The following is a description of a gene set: The process in which an antigenically naive T cell acquires the specialized features of an effector, regulatory, or memory T cell as part of an immune response. Effector T cells include cells which provide T cell help or exhibit cytotoxicity towards other cells. Mouse Gene Set: GOBP_T_CELL_DIFFERENTIATION_INVOLVED_IN_IMMUNE_RESPONSE species: Mus musculus, and this is the list of marker genes: Il27, Clec4e, Socs5, Rorc (RAR-related orphan receptor gamma), Mir873a, Smad7, Il4, Tmem98, Myb, Mir326, Malt1, Ccl20, Nfkbiz, Rara, Cracr2a, Spn, Pck1, Entpd7, Brd2, Ptger4, Rora, Mtor, Stat4, Shb, Tbx21 (T-box 21), Irf4, Nfkbid, Hmgb1, Mir301, Zbtb7b, Prkcz, Tnfsf18, Zc3h12a, Ccr6, Il6, Il6ra, Pf4, Il4ra, Batf, Tbk1, Ep300, Lef1, Men1, Relb, Atp7a, Eomes, Il18, Ccr7, Clec4d, Il18r1, Rc3h2, Stat3, Loxl3, Il12b, Slamf6, Zfp35, Il23a, Bcl6, Pik3r1, Fgl2, Ripk2, Gadd45g, Ifng, Itgb6, Kmt2a, Gpr183, Otud5 (OTU domain containing 5), Tsc1, Il21, Foxp1, Ccl19, Ccr2, Opa1, Gata3, Foxp3, Itgb8 (integrin beta 8), Tgfb1, Jak3, Ascl2, Cd69, Rc3h1, Irf1, Nlrp3, Bcl3, Cd46, Hlx (H2.0-like homeobox), Fcer1g, Tnfsf4, Stat6, H2-Ea, Il2, Brd4, Sema4a, Lgals1, Anxa1, Ly9